The following is a description of a gene set: Facial asymmetry Human Gene Set: HP_FACIAL_ASYMMETRY An abnormal difference between the left and right sides of the face. species: Homo sapiens, and this is the list of marker genes: FANCG, BRCA1, FANCB, SLC12A6, CTNND1, IDH1, H19, HRAS, DACT1, FRAS1, SMC3, KCNJ5, NSD2, TRIO, GDF6, CPLX1, USP9X, EBF3, ELOVL4, SMO, MEOX1, FGF9, FANCE, PKD2, PLCB4, XRCC2, ELMO2, FANCA, PAX1, ANOS1, RAD51C, FANCM, RFX7, FANCF, RNU4-2, SIX1, PIK3CA, SLX4, KMT2D, NFIX, GNAI3, MACF1, MAF, FANCD2, ERCC4, EYA1, FGFRL1, KDM4B, MAN2C1 (NCBI Gene Id 4123), MYH3, MAD2L2, NOG, FANCI, KCNJ2, LETM1, FLI1, TWIST1, EDNRA, FGFR3, COL2A1, KAT6A, FN1, PSMD12, MAFB, NRAS, PALB2, NTRK2, YY1, PUF60, PURA, RAD51, EFNB1, RFWD3, UBE2T, ZIC1 (NCBI Gene Id 7545), MAPK1, FLNA, CHRNG, SMC1A, IGF2, RHOA, SLC37A4, ASPH, SF3B2, NEUROG1, LRP4, SALL4, CRKL, CLTCL1, NBAS, STAT3, POLR1A, SMS, SIX5, BMP4, PIGN, SIN3A, SEPTIN9, CDK13, KRAS, PIGA, CDH11, GNAS, MYCN (MYCN proto-oncogene, bHLH transcription factor), SF3B4, HDAC9, AKT2, GLI2, PPP2R1A, SOX5, POLR1B, NF1, SON, FANCL, MYH8, SATB2, TRPM3, EBP, SP7, PIEZO2, FANCC, PORCN, COL1A1, GUSB, CHD7, BCR, CTBP1, SEMA3E, OFD1, BRIP1, TGFBR1, PPP2R5D, KCNQ1OT1, CHN1, ATR, CEP85L, GDF3, SALL1, ADAT3 (NCBI Gene Id 113179), FGFR2, CEP152, SET, EDN1, CHST14, PTH1R, DDX59, DHX37, AKT1, GDF5, BRCA2, KMT2A, IDH2